Given this list of marker genes EFNB3, ZMPSTE24, SCN1A, CWH43, ZNF212, DAB1, HTRA2, ABHD12, HEXA, BORCS7, NPC1, FKRP, KCNJ10, FXN, CHD7, CTNS, EPHA4, GBX1, CEND1, ARRB2, OXR1, GLRB (NCBI Gene Id 2743), GLRA1, AGTPBP1, SPG11, CACNB4, LARGE1, RNF170, DMRT3, DRD2, ZIC1, CNTN2, CLN8, HIPK2, DRD1, MINAR2, SPTBN4, TRH, KLHL1, UCHL1, here is a description of the gene set: species: Homo sapiens Human Gene Set: GOBP_WALKING_BEHAVIOR The behavior of an organism relating to the progression of that organism along the ground by the process of lifting and setting down each leg.